The following is a description of a gene set: Gene expression profiles of subsets of CD4+ T cells according to their expression of FoxP3 and CD45RA were compared. FoxP3 is a key transcription factor for the development and function of natural CD4+ regulatory T cells (Tregs). Here we show that human FoxP3+CD4+ T cells are composed of three phenotypically and functionally distinct subpopulations: CD45RA+FoxP3low resting Tregs (rTregs) and CD45RA-FoxP3high activated Tregs (aTregs), both of which are suppressive in vitro, and cytokine-secreting CD45RA-FoxP3low non-suppressive T cells. The proportion of the three subpopulations characteristically altered in cord blood, aged individuals, and patients with immunological diseases. Terminally differentiated aTregs rapidly die while rTregs proliferate and convert into aTregs in vitro and in vivo as shown by the transfer of rTregs into NOD-scid-common gamma-chain-knockout mice and by TCR sequence-based T cell clonotype tracing in peripheral blood of normal individuals. Taken together, the dissection of FoxP3+ cells into subsets enables one to analyze Treg differentiation dynamics and interactions in normal and disease states, and to control immune responses through manipulating particular FoxP3+ subpopulations. from publication Miyara M, Yoshioka Y, Kitoh A, Shima T, Wing K, Niwa A, Parizot C, Taflin C, Heike T, Valeyre D, Mathian A, Nakahata T, Yamaguchi T, Nomura T, Ono M, Amoura Z, Gorochov G, Sakaguchi S (PMID 19464196) Genes down-regulated in comparison of naive CD4 T cells versus PTPRC+ CD4 T cells. Human Gene Set: GSE15659_NAIVE_VS_PTPRC_NEG_CD4_TCELL_DN species: Homo sapiens, and this is the list of marker genes: AFG2B, RHBDF2, SLC9A5, UBE4B, SULT1C2, TFF2, TAS2R9 (NCBI Gene Id 50835), TBC1D4, TMEM63C, SCO2, VCPIP1, POLR1H, VSTM1, RTP1, STK36, SH2D1A, UNC13D, RBM25 (RNA binding motif protein 25), SPATA12, SYT14, PRDM13, SOX11, TNFSF12, PXDNL, VPS35, SCN8A, YIPF2, TSNAX, RAMP1, WARS1, ZNF861P, S1PR2, WDR13, ZNF644, TRIML1, TOP3A, PTH2R, PYGL, SERF1A, PPIC, TIMP1, SCARF2, TRAK1, RTP3, TRIM72, SHB, PVR (NCBI Gene Id 5817), USP43, YAP1 (NCBI Gene Id 10413), S100P, PRKCE, IL13RA2, BAZ1A, RASD1, UBE2J1, PSRC1, EMC2, TCP10L3, HACD4, TP63, TRIP12, PPP2R5A, PTPN18, TMEM125, SPACA7, RAB35, TLL2, SAP30BP, RAB2B, PROCR, TMEM139, SUSD1, TMBIM1, SLC9A6, SLC43A3, SEC23B, RPE65, ZCCHC13, WDR33, DESI2, SAMSN1, SRL, THRB, ZNF385D, ROPN1B (rhophilin associated tail protein 1B), ARHGAP42, UBE2U, TIFAB, VAMP3, TRIM54, TTC33, UBL7, DENND2B, RHBDL2, PRRG3, GET1, PPP2CA, UTS2B, TLCD1, SDS, SLC44A3, ZNRF2, RBM28, ZNF488, TMEM126A, TIMM17A, TP53INP2, ZAN, SCGB3A2, ZNF44, ZMIZ2, ZIC1, TLR1, TLR4, RAB9A, PTPRT, UBE2D1, RRM1, TLX3, TTTY13, SPCS2, SLC24A5, ZNF142, VIPR2, RNASET2, SNAI2, SNAP91, SHMT2 (serine hydroxymethyltransferase 2), TNFAIP3 (TNF alpha induced protein 3), ROCK1, SLC22A1, RNF167 (NCBI Gene Id 26001), TMCO5A, THBD, RASA1, TULP2, SCEL, TPI1, ZNF414, SPATA2, SEC24D, SEC61B, TDRD7, NECTIN4, RHOU, RASL11A, TSEN54, TPMT, RNF19A, RSPH10B2, DNAAF10, PRAMEF12, TINF2, S100A16, PPM1K, ZSCAN9, SNX3, TBCCD1, SERHL2, PSEN1, VEGFB, ZPBP2, UBA6, PRG3, PRKX, SLC25A3, TRIM2, SYCE1L, RIT1, TRIM16, RANBP9, SPATA22, TRAPPC6B, ST6GALNAC1 (NCBI Gene Id 55808), SNAI3, STARD4, SPATS2L, SLC4A9, TTTY6, SMAD6, TRPM6, TP53I13, PPEF2, PRR9, RPL3L, ST7-AS1 (ST7 antisense RNA 1), ZBED6, RBPMS, TRIM36, TUBB4B, SEMA7A, LINC01121, ZDHHC8BP, STC2, SLC4A2, SNORA65, TBX3, SCAMP5, PRDX4, RGL3